Given this list of marker genes SLFN11, FAM81A, DCLK2, LPL, NEUROD2, DMRT2, PDGFRA, DHH, COL24A1, TMEM132E, SRD5A2, SLCO2A1, ZIC4 (NCBI Gene Id 84107), MAPT, PTGER3 (NCBI Gene Id 5733), OTOP1, CRYBA2, HES7, NBPF11, FOXF1, PDZD2, SLC30A4, RPRML, ERICH5, DLX4, DKK1, PYY, NEUROG2, KCNQ3, SOX7, PCDH8, CRTAC1, NTRK1, EOMES, PTF1A, RGS20, FOXB1, TBR1, NT5C1A, CBR3, TBX21, RGS9BP, CLEC14A, GPR88, ADRA1A, BHLHE22, ITPKA, LRFN5, DMRT3, GPR101 (G protein-coupled receptor 101), DLX3, NTRK2, FGF3, HHEX, VSX1, WNT16, PTHLH, CTNND2, NPAS1, ADRA2A, BARHL1, LAYN (layilin), PABPC1L2A, RTN4RL2, SCN4B, GRIA2, GPC5, NAGS, VSX2, COMP, CYP26C1, CMTM2, ESX1, HOXD4, ADGRL3, HOXD3, ESAM, TFAP2E, PODN, ZEB2, EGR3, FGF20, CACNA1G, TRPC5, DCC, KCND3, HOXB2, ADCYAP1, SPON1, SCNN1G, RASL10A, CLCN5, INSRR, FRMPD4, SERTM1, CSMD1, IGF2-AS, FOXL1, CHODL, DNAJC22, SOX14, CAMK2N1, RYR3, BARX2, RIPK3, NKX2-3, UCP1, SUSD4, ASCL2, FAM89A, NEFL (NCBI Gene Id 4747), LRRTM1, LHX2, DSC3, TP73, MYO5B, KY, FZD10, IGSF21, HSPA6, PDX1, KL, NDUFA4L2, HTR2C, BNC1, HAND2, FGF5, PAX2, SLC24A4, MT1M, SHOX2, OTOP2, ANKRD20A8P, HOXB8, GJD2, HBA1, FFAR4, EFNA1, WNT10A, LAMP5 (NCBI Gene Id 24141), DPY19L2, DLX1, BRINP3, SGPP2, POU4F2, MYF6, VAX2, NEUROD1, SFRP1, GHSR, CDH23, MAB21L2, ANKRD27, FAM163A, RASSF5, WNT2, ONECUT1, GUCY2D, MLLT3, TAL1, AQP5, MAL, DIO3, UCN, SV2B, ZNF436, SHOX, BARHL2, GRIK3, SIDT1, EN1, HS3ST3B1, TBX1, SLC32A1, FEZF2, WT1, HOXC6, WRAP73, ILDR2, HHAT, NR4A3, DPF3, CIDEA, EPB41L4A-DT, ALOX15, NKX2-1, SATB2-AS1, INSM2, FOXD4L4, TMEFF2, MESP1, ARL9, ADARB2, NCAM1, KCNK4, EN2, OLFML2B, ADCY4, GSX1, GALNT18, CNNM1, DGKG, OAF, DKK2, NPR3, CRLF1, TRIM67, SSTR1, ADRB1, SLC26A4, KCNH1, JUN, GABRA4, ANKRD20A2P, HOXB3, RSPO2, NKX2-2, IRX5, USH1G, NR2F2, HS6ST3, PENK, ARHGAP20, LHX5, TMEM132E-DT, CYP26A1, ANKRD20A5P, PPM1E, TRIM9, MAFB, LHX4, ANKRD18B, SCD5, NELL1, WNT3A, EPHA5, BRINP2, GPR12, TBX5, LRCH2, SLIT1, COL9A2, DRD5, SIM2, CD34, GAD2, OCA2, FBXL8 (F-box and leucine rich repeat protein 8), DUOXA2, SCTR, BMP8A, HOXB1, STMN2, CBLN4, CRHR1, HTR1A, SLC1A2, FOXD2, CBX8, PTGER2, TTYH1, MSC, MNX1, SLC27A2, NKX6-2, COL4A5, GUCY1A1, ATOH8, MAPK4, ASCL1, ONECUT2, FOXD4L1, PHOX2A, ELAPOR1, CNTFR (NCBI Gene Id 1271), FOXD3, RSPO1, CITED1, DCHS2, FEZ1, THBD, EVA1C, BATF3, PCDH17, HMX2 (H6 family homeobox 2), GATA3, SLC30A3, IL1RAPL2, C2CD4A, SIX6, VDR (NCBI Gene Id 7421), DOK6, HLX, LBX1, DSCAML1, RNF128, NPNT (nephronectin), PITX3, POU4F1, GATA6, INA, SPAG6, OLIG2, OTX1, HHIP, COLGALT2, CDX2, FZD2, GRM7, RPS6KA6, GABRA2, CHST8, HEY1, GJB2, NFIX, LMX1B, TRIM36, KCNC2, B4GALNT1 (NCBI Gene Id 550623), ROBO3, WNT11, F2R, SLC9A3, HTR7, COL2A1, HNF1B, KCNK2, ALX3, CLSTN2, PTGR3, ADAP2 (ArfGAP with dual PH domains 2), NTNG2, ANKRD19P, FUT4, ST8SIA2, NKX3-2, MIR137HG, FOXG1, KCNA3, CXCL14, LTBP2, ESPN, MKX, ISL2, ISL1, PHOX2B, CACNA1D, DLL4, STXBP6, PGR, KIRREL3, GPM6B, PAX1, PTGFR, COL25A1, PIR, SIX3, LHX6, CHRD, NOL4, GHR, CALCA, TRH, ASTN2 (NCBI Gene Id 23245), KCNK13, TLX1, ADRB3, HOXD12, HOXD9, ELMOD1, SHC4, ZFYVE28, RAX, KCNMA1, SLC6A1, NPY1R, SIX2, ATOH1, GSC2, LRRC71, PAX3, BCL2, OTOP3, HOXB6, RIMKLA, ECEL1, LHX8, GDNF, SLC6A5, HBA2, MT1H, SLC6A3, GSX2, MSX1, WNT10B, HOXC11, SOX17 (SRY-box transcription factor 17), FBLN7, FRMD3, CEMIP, COL27A1, TMOD2 (NCBI Gene Id 29767), POU3F1, GDF6, ZNF436-AS1, ZBTB16, PXMP2, FIGLA, CDH7, PLEC, FOXL2, ICAM5, PMP22, RTL4, ERBB4, PTPRT, DUSP4, PROK2, KCNC4, UNC5C, VAX1, DACH1, HOXC8, BHLHE23, CACNA1E, SLC30A2, METRNL, SEMA6D (NCBI Gene Id 80031), NTN1, RIMBP3B, PRLHR, FBXO3, TSLP, DLX2, MGARP, DDAH1, SLIT2, CCDC140, PARM1, DPY19L2P2, BHLHE41, FOXJ1, B4GALNT2, HOXD8, TAFA4, COLEC12, DUOXA1, OPRD1, FBN2, GBX2, SPOCK3, SYT12, GATA4, CFAP91, CA10, LGR5, FBP1, MT1B, PKP1, CBLN1, CYP26B1, ANXA2R, LTK, TPPP3, CH25H, ABTB2, SLC35F3 (solute carrier family 35 member F3), TBX3, FLI1, PITX1, TLL1 (tolloid like 1), TMEM30B, CDK5R2, GALR2, CASZ1, ADAMTS18, HPSE2, WNT6, MYOD1, GDF7, PGM5, PRDM12, EPAS1, FEV, CGB7 (chorionic gonadotropin subunit beta 7), WNT7A, EPB41L4A, CYP27B1 (cytochrome P450 family 27 subfamily B member 1), SLC9A2, GATA3-AS1, LINC02875, LGALS3, PAX6, ANKRD20A1, COL4A6, PTGDR, NRG2, ZMYND15, PAX8, ADAMTS15, CXCL16, PIP5K1B, KLF4, CGB8, NKX2-8, KCNAB1, PAX7, CYP24A1, IRX4, ANKRD18A, PTPRU, CHRDL2, HOXC12, TET2, GIMAP5, FOXA2, MT1DP, PRKCE, PKNOX2, GRIK1, NPTX1, BTG2, STK32B, RGS10, FLRT2, NPAS4, POU3F4, FOXD4L3, RIMBP3, HMX3, KLHL35, PTGER4, CACNA1B (NCBI Gene Id 774), FAM43B, MT1A, ANKRD20A3P, POLE, ASTN1, HPCAL4, OXCT2, FGF9, PRAC1, EGR4, ZIC1, ZFHX3, RASGRF1 (NCBI Gene Id 9983), HOXD13, LRP2, HES2, ZNF503, CD8A, MCOLN3, KCNA1, TRADD, NKX3-1, ANXA2R-AS1, VASH1, SLCO5A1, RAB6C, ENSG00000255537, IRX3, GATA2, NRG1, KCNH3, TCEA3, HRK, PIGZ, ALX4, EGFL6 (NCBI Gene Id 25975), SORCS1, GPAT3, NKX6-1, DGKI, LYSMD2, WNT1, LRATD1, HOXB7, DMRT1, EPHB3, CLTRN, PITX2, MAB21L1, DACH2, CORO6, RGCC, OTP, ITGA4, NEFM, SIX1, RIMBP3C, SLITRK3, TMEM59L, FOXE1, EFNA3, CDKN2C, TMEM88, SFRP5, SHH, IL7, SORCS3, PAPPA, DUOX2, SLITRK1, CFAP276, LONRF3, DUOX1, PDE4DIP, HOXD1 (NCBI Gene Id 3231), HOXC5, CNRIP1 (cannabinoid receptor interacting protein 1), EPHB1, OTX2, GRIN3A, TBX2, CSMD3, PAX9, PLXNA2, OSR1, POU4F3, WT1-AS, SHISA6, NEUROG1, SSTR2, GRID1, HOXC4, ATF3, TLX2, KCNK12, CD70, NAV2, NEUROG3, BARX1, RBP4, KAZALD1, REPS2, ALKAL1, SLC1A4, SLC10A4, GNA14, PLPPR1, HS6ST1P1, ADCY8, KCNV1, IKZF3, PTH2, HSF4, ABCC8, GSC, HOXB13, PRKG1, here is a description of the gene set: Cancer cells possess traits reminiscent of those ascribed to normal stem cells. It is unclear, however, whether these phenotypic similarities reflect the activity of common molecular pathways. Here, we analyze the enrichment patterns of gene sets associated with embryonic stem (ES) cell identity in the expression profiles of various human tumor types. We find that histologically poorly differentiated tumors show preferential overexpression of genes normally enriched in ES cells, combined with preferential repression of Polycomb-regulated genes. Moreover, activation targets of Nanog, Oct4, Sox2 and c-Myc are more frequently overexpressed in poorly differentiated tumors than in well-differentiated tumors. In breast cancers, this ES-like signature is associated with high-grade estrogen receptor (ER)-negative tumors, often of the basal-like subtype, and with poor clinical outcome. The ES signature is also present in poorly differentiated glioblastomas and bladder carcinomas. We identify a subset of ES cell-associated transcription regulators that are highly expressed in poorly differentiated tumors. Our results reveal a previously unknown link between genes associated with ES cell identity and the histopathological traits of tumors and support the possibility that these genes contribute to stem cell-like phenotypes shown by many tumors. Set 'PRC2 targets': Polycomb Repression Complex 2 (PRC) targets; identified by ChIP on chip on human embryonic stem cells as genes that: posess the trimethylated H3K27 mark in their promoters and are bound by SUZ12 and EED Polycomb proteins. species: Homo sapiens Human Gene Set: BENPORATH_PRC2_TARGETS from publication Ben-Porath I, Thomson MW, Carey VJ, Ge R, Bell GW, Regev A, Weinberg RA (PMID 18443585)